Given this list of marker genes Kcnk1, Asic3, Rab11fip5, P2rx5, Insrr, Gja3, Ttpa, Serpinf1, Arsa, Kcne1, Sts, Gpr65, Slc9a1, Gja1, Src, Kcnma1, Kcnk4, Gpld1, Scnn1b, Mcoln1, Gpr4, Gba1, Arsb, Asic1, Tg, Clcn7, Pkd1l3, Pck1, Gh, Gna11, Scnn1g, Lgmn, Gpr31b, Pkd2l1, Gpr151, Kcnk9, Acer1, Chp1, Trpv1, Kcnk3, Sst, Scnn1a, Kcnk18, Hyal1, Asic2, Pam, Ctss, Slc38a3, Abcc8, Gip, Rab11b, Gpr68, Hvcn1, here is a description of the gene set: species: Mus musculus Mouse Gene Set: GOBP_RESPONSE_TO_PH Any process that results in a change in state or activity of a cell or an organism (in terms of movement, secretion, enzyme production, gene expression, etc.) as a result of a pH stimulus. pH is a measure of the acidity or basicity of an aqueous solution.